Given this list of marker genes CHSY1, PIGH, CKAP2L, SALL1, KCNJ2, ALG3, KCNJ5, FRA10AC1, DLEC1, WWOX, RNF6, HEPHL1, RAB3GAP2, PPP1R15B, TGFBR2, TRMT10A, here is a description of the gene set: Human Gene Set: HP_DEVIATION_OF_THE_5TH_TOE studied in species Homo sapiens Deviation of the 5th toe